Given this list of marker genes ADGRG1, ALDH1A1, CDKN1C, TAGLN, FILIP1L, CNN1, NREP, MYL9, GLS, DAB2, here is a description of the gene set: Genes up-regulated in RCC4 cells (renal cell carcinoma) engineered to stably express VHL off a plasmid vector. from publication Maina EN, Morris MR, Zatyka M, Raval RR, Banks RE, Richards FM, Johnson CM, Maher ER (PMID 15824735) Upregulation of hypoxia-inducible factors HIF-1 and HIF-2 is frequent in human cancers and may result from tissue hypoxia or genetic mechanisms, in particular the inactivation of the von Hippel-Lindau (VHL) tumour suppressor gene (TSG). Tumours with VHL inactivation are highly vascular, but it is unclear to what extent HIF-dependent and HIF-independent mechanisms account for pVHL tumour suppressor activity. As the identification of novel pVHL targets might provide insights into pVHL tumour suppressor activity, we performed gene expression microarray analysis in VHL-wild-type and VHL-null renal cell carcinoma (RCC) cell lines. We identified 30 differentially regulated pVHL targets (26 of which were 'novel') and the results of microarray analysis were confirmed in all 11 novel targets further analysed by real-time RT-PCR or Western blotting. Furthermore, nine of 11 targets were dysregulated in the majority of a series of primary clear cell RCC with VHL inactivation. Three of the nine targets had been identified previously as candidate TSGs (DOC-2/DAB2, CDKN1C and SPARC) and all were upregulated by wild-type pVHL. The significance for pVHL function of two further genes upregulated by wild-type pVHL was initially unclear, but re-expression of GNG4 (G protein gamma-4 subunit/guanine nucleotide-binding protein-4) and MLC2 (myosin light chain) in a RCC cell line suppressed tumour cell growth. pVHL regulation of CDKN1C, SPARC and GNG4 was not mimicked by hypoxia, whereas for six of 11 novel targets analysed (including DOC-2/DAB2 and MLC2) the effects of pVHL inactivation and hypoxia were similar. For GPR56 there was evidence of a tissue-specific hypoxia response. Such a phenomenon might, in part, explain organ-specific tumorigenesis in VHL disease. These provide insights into mechanisms of pVHL tumour suppressor function and identify novel hypoxia-responsive targets that might be implicated in tumorigenesis in both VHL disease and in other cancers with HIF upregulation. species: Homo sapiens Human Gene Set: MAINA_VHL_TARGETS_UP